Given this list of marker genes HMGCS2, TRIL, GPD1L, SCUBE2, ABCA12, SERHL2, SERHL, KCNMA1, PRLR, CPD (carboxypeptidase D), MLPH, RND1, SULT1A2, GALNT6, CIRBP, CRAT, RHOB (NCBI Gene Id 388), BRINP3, PIP, GGT1, SIDT1, TNXA, TFF3, FA2H, CRISP3, CERS4 (ceramide synthase 4), TFAP2B, ALDH4A1, TOX3, MPHOSPH6, FGFR4, FAM174B, SLC16A2, LASP1, NEIL1, HGD, PEX11A, TRGC1, SPDEF, DCXR, NFIA, REEP5, C1orf115, HPX, PDCD4, CCNDBP1, DHRS2, ALDH3B2, FASN, TRIM3, TBC1D9, ABCA8, BMERB1, ABCC6, CEACAM6, CYP4F8, ECHDC2, AZGP1, CYB5A, APOD, LRRC31 (leucine rich repeat containing 31), CDK12, KMO, TNIK, GALNT7, CLCA2, ALCAM, AR, RASL10A, AGR2, PBLD, LRIG1, here is a description of the gene set: Genes up-regulated in ER(-) / PR(-) breast tumors (do not express ESR1 and PGR) with molecular similarity to ER(+) (class A) relative to the rest of the ER(-) / PR(-) samples (class B). from publication Doane AS, Danso M, Lal P, Donaton M, Zhang L, Hudis C, Gerald WL (PMID 16491124) Human Gene Set: DOANE_BREAST_CANCER_CLASSES_UP Little is known of the underlying biology of estrogen receptor-negative, progesterone receptor-negative (ER(-)/PR(-)) breast cancer (BC), and few targeted therapies are available. Clinical heterogeneity of ER(-)/PR(-) tumors suggests that molecular subsets exist. We performed genome-wide expression analysis of 99 primary BC samples and eight BC cell lines in an effort to reveal distinct subsets, provide insight into their biology and potentially identify new therapeutic targets. We identified a subset of ER(-)/PR(-) tumors with paradoxical expression of genes known to be either direct targets of ER, responsive to estrogen, or typically expressed in ER(+) BC. Differentially expressed genes included SPDEF, FOXA1, XBP1, CYB5, TFF3, NAT1, APOD, ALCAM and AR (P<0.001). A classification model based on the expression signature of this tumor class identified molecularly similar BCs in an independent human BC data set and among BC cell lines (MDA-MB-453). This cell line demonstrated a proliferative response to androgen in an androgen receptor-dependent and ER-independent manner. In addition, the androgen-induced transcriptional program of MDA-MB-453 significantly overlapped the molecular signature of the unique ER(-)/PR(-) subclass of human tumors. This subset of BCs, characterized by a hormonally regulated transcriptional program and response to androgen, suggests the potential for therapeutic strategies targeting the androgen signaling pathway. studied in species Homo sapiens